Given this list of marker genes THRSP, ALDH1A1, CYP26A1, SLC10A1 (NCBI Gene Id 6554), AR, CYP7A1, PRLR, FGF1, here is a description of the gene set: studied in species Mus musculus from publication Khetchoumian K, Teletin M, Tisserand J, Mark M, Herquel B, Ignat M, Zucman-Rossi J, Cammas F, Lerouge T, Thibault C, Metzger D, Chambon P, Losson R (PMID 18026104) Hepatocellular carcinoma (HCC) is a major cause of death worldwide. Here, we provide evidence that the ligand-dependent nuclear receptor co-regulator Trim24 (also known as Tif1alpha) functions in mice as a liver-specific tumor suppressor. In Trim24-null mice, hepatocytes fail to execute proper cell cycle withdrawal during the neonatal-to-adult transition and continue to cycle in adult livers, becoming prone to a continuum of cellular alterations that progress toward metastatic HCC. Using pharmacological approaches, we show that inhibition of retinoic acid signaling markedly reduces hepatocyte proliferation in Trim24-/- mice. We further show that deletion of a single retinoic acid receptor alpha (Rara) allele in a Trim24-null background suppresses HCC development and restores wild-type expression of retinoic acid-responsive genes in the liver, thus demonstrating that in this genetic background Rara expresses an oncogenic activity correlating with a dysregulation of the retinoic acid signaling pathway. Our results not only provide genetic evidence that Trim24 and Rara co-regulate hepatocarcinogenesis in an antagonistic manner but also suggest that aberrant activation of Rara is deleterious to liver homeostasis. Human Gene Set: KHETCHOUMIAN_TRIM24_TARGETS_DN Retinoic acid-responsive genes down-regulated in hepatocellular carcinoma (HCC) samples of TRIM24 knockout mice.